Given this list of marker genes ATP13A3, EMC9, SPAG9, P4HB, TRAF3, PATL1, EIF4A3, EP400P1, TCAF2, IER3, DUSP3, GNA15, SIAH2, B3GNT5 (NCBI Gene Id 84002), SLC15A3, ERO1A, ZNF395, INSIG1, ZC3H7A, ATP6V1C1, KLF10, TNFAIP3, RNF103 (NCBI Gene Id 7844), MAP3K13, BANP (BTG3 associated nuclear protein), MTFP1, TFDP1, LIMS3, RBPJ, CCNG2, PPCDC, TGM3, HPCAL1, SKIL, SLC3A2, SNN, VNN3P, BCL2A1, USP28 (ubiquitin specific peptidase 28), CNOT2, WDR45B, SNX8, FUT11, DIABLO, GADD45B, NUP58, STAT4, ZC3H12A, RGL1, SERP1, AMPD3, QKI, DARS1, SGSH, MFSD12, HIVEP2, LAMB3, NANOS3, GNPDA1, SERPINB9P1, AZIN1, TMF1, SEC31A, NFKBID, BRD4, OXSM, CHD2, LSM12, PLAUR, VDAC2, ZMIZ1, PHC1, MXI1, ALKBH5, FBXO34, SGTB (NCBI Gene Id 54557), ADM, MAP1LC3B, ATG12, NDST2 (NCBI Gene Id 8509), CFDP1, TENT4A (NCBI Gene Id 11044), DENND5A, PPP1R3E, RREB1, FTH1, SGF29, ADIPOR2, BCOR, ENO1 (NCBI Gene Id 81977), SNAPC1, STARD8, STX4, SAV1, LPCAT1, ZNF277, ERMN, PDK1, PHTF1, HSD17B4 (hydroxysteroid 17-beta dehydrogenase 4), HPS5, PRXL2B, SLC15A4, ASCC1, RAB8B, VPS18, PHF1, NFKBIE, EDEM1, CDC37, IL2RG, ZHX2 (NCBI Gene Id 22882), C9orf72 (C9orf72, member of C9orf72-SMCR8 complex), OLR1, SETD5, TXNDC11, MEI1, CNTROB, RELA, ATP1A1, ARL5B, CDK2 (cyclin dependent kinase 2), GRINA, LGALS3, KMT2E, TNFRSF14, CD83, NBEAL1, RIMKLA, RIMKLB, BRAF, GZF1, EIF4A1, RAB21, MAPK6, SLC35B2 (solute carrier family 35 member B2), TMEM268, MTCH2, OXSR1, PTGES, NAB1, MFAP1, KDM5B, NAPA, RASSF5, HEXA, ATG2A, CLN3 (CLN3 lysosomal/endosomal transmembrane protein, battenin), LATS2, PRR5L, GUK1, DDIT3, SLC2A3, KANSL3, DDX41, LINC00847, NR1D2, ATP6V1F, PPME1 (NCBI Gene Id 51400), HMGA1, STX6, BNIP3L, CIDEC, KCNAB2, WBP11, GGT1, ABCF1, PIP4P1, GABARAPL1, ZBTB25, RAB33A, CHMP4A, ARRDC2, PDE4B, AKAP10, IER5, SUCNR1, ANAPC16, CHMP4B, CRTC2, MCOLN1 (mucolipin TRP cation channel 1), ZMYND15, USP37, CD63, TGIF2, GCFC2, MAPK1IP1L, ZBTB1, VEGFB, MAFF, SLC43A3, TBC1D7, FKBP15, WDR54, SOD2, GGA1, RAPGEF6, TFRC, PIK3IP1, here is a description of the gene set: from publication Schwartz JT, Bandyopadhyay S, Kobayashi SD, McCracken J, Whitney AR, Deleo FR, Allen LA (PMID 22986450) We demonstrated recently that both constitutive and FAS-triggered apoptosis of human neutrophils are profoundly impaired by Francisella tularensis, but how this is achieved is largely unknown. To test the hypothesis that changes in neutrophil gene expression contribute to this phenotype, we used human oligonucleotide microarrays to identify differentially regulated genes in cells infected with F. tularensis strain LVS compared with uninfected controls. In order to examine the effect of F. tularensis on the neutrophil transcriptome, we performed microarray expression analysis on human neutrophils treated with F. tularensis subsp. holarctica live vaccine strain (LVS). species: Homo sapiens Human Gene Set: GSE37416_0H_VS_12H_F_TULARENSIS_LVS_NEUTROPHIL_DN Genes down-regulated in comparison of control polymorphonuclear leukocytes (PMN) at 0 h versus PMN treated with F. tularensis vaccine at 12 h.